The following is a description of a gene set: Mouse Gene Set: GOBP_PRESYNAPTIC_MEMBRANE_ORGANIZATION studied in species Mus musculus A process which results in the assembly, arrangement of constituent parts, or disassembly of a presynaptic membrane, including any proteins associated with the membrane, but excluding other cellular components. A presynaptic membrane is a specialized area of membrane of the axon terminal that faces the plasma membrane of the neuron or muscle fiber with which the axon terminal establishes a synaptic junction., and this is the list of marker genes: Nlgn4l, Cntn2, Nlgn2, Apoe, Nlgn1, Il1rapl1, Nrxn1, Ptprd, Lrp4, Nlgn3, Pten, Lrrtm4